The following is a description of a gene set: species: Homo sapiens Systems vaccinology has emerged as an interdisciplinary field that combines systems wide measurements and network and predictive modeling applied to vaccinology. Here we used the systems vaccinology approach to study the molecular mechanisms underlying th Genes up-regulated in comparison of plasmacytoid dendritic cells (DC) from influenza vaccinee at day 7 post-vaccination versus myeloid DCs at day 7 post-vaccination. from publication Nakaya HI, Wrammert J, Lee EK, Racioppi L, Marie-Kunze S, Haining WN, Means AR, Kasturi SP, Khan N, Li GM, McCausland M, Kanchan V, Kokko KE, Li S, Elbein R, Mehta AK, Aderem A, Subbarao K, Ahmed R, Pulendran B (PMID 21743478) Human Gene Set: GSE29618_PDC_VS_MDC_DAY7_FLU_VACCINE_UP, and this is the list of marker genes: SLC20A1, GNG7, CIB2 (NCBI Gene Id 404086), COBLL1, TPM2 (tropomyosin 2), ITM2C, MAN1A1, PMS2P2, SEPHS1, HIVEP1, PMS2P5, SCAMP5, HIGD1A, ANKRD36, SLC7A11, TEX2, TCL1A, ENTPD4 (NCBI Gene Id 9583), PRKCB, RUNX2, ODC1, PDCD4, CREB3L2, PDIA4, EGLN3, NUCB2, SEC61A2, ADAM19, NFYA, RUBCNL, NOTCH4, RGS7, B4GALT1, SRP14, PNOC, MYB (MYB proto-oncogene, transcription factor), DAPK2, UBE2E3, SSR3, MDFIC, LAMP5, CERS6, ALOX5AP, IRF8, OFD1, PTK7, TSPAN3, RMC1, BTG3, PHEX, KCNA5, CRIM1, SCARB2, IGKC, ADA, UBE2J1, TM9SF3, RPS6KA2, CMKLR1, AQP3, CYFIP2 (cytoplasmic FMR1 interacting protein 2), TRAF4, TBC1D4, PAFAH2, SLC39A6, SIDT1, PCDHGA3, GGA2, GGH, CDC14A, GPM6B, PLAC8, WASF1, PLP2, GRAMD1B, GZMB, SERPINF1, P2RY14, IGF2R, WDR19, CUEDC1, FLNB, ATP13A2, SNHG20, MAP1A, BCL11A, ATXN7L3B, SMPD3, FCHSD2, CYBB, IL3RA, RRBP1, LILRB4, DAB2, MARCHF2, ZDHHC17, TSPAN13, FAM30A, HHAT, DUSP5, SMC6, SLC7A5, RIPOR1, PMS2P1, CUX2, ST3GAL2, APP, CD2AP, HSP90B1, RHOH, CD164, PLAAT3, SETBP1, MAP2K6, IFIT2, DACT1, ENPP2, SEL1L3, GFI1, MREG, TCF3, TM9SF2, NPC2, ANKRD36B, EPHB1, HERC5, TNFRSF21, DCK, IDH3A, LHFPL2, CRYM, DACH1, TAF9B, ATP2A3, ALDH5A1, USP11, TGFBI, SIT1, MGAT4A, IGHM, MZB1, GAS6, SNRNP25, PPIB, NGLY1, USP24, PARK7, TLR7, AEBP1, PTGDS, UGCG, SFT2D2, PPP1R14B, HYOU1, LAMP1, SEC61G, PTPRS, KRT5, OGT, AHI1, PLEK, CCNYL7, KMO (NCBI Gene Id 8564), CBFA2T3, BBIP1, SCT, ZNF589, POLB, BLNK, PPP1R16B, DAAM1, PTPRCAP (NCBI Gene Id 5790), NRP1, IRF7, AUTS2, KCNK10, FHL1, SPCS1, ZHX2, MAGED1, LBH, SEC61B (NCBI Gene Id 10952), STMN1, MAPKAPK2, JCHAIN, PTBP3, CDK5R1, LAIR1, LILRA4, STK32B, CSF2RB, TCF4, SCN9A, RAB15, ARF1, DIDO1, ACSL3, AHNAK2, SSR4